Given this list of marker genes MYRF, CFL2, SACM1L, RGS3, HERC6, SBF2, RIN2, EIF4A2, FNDC3B, INHBB, NBEAL1, BAZ2A, DNAJB11, CELF2, NAA50, CSTF3, MAP4K4, VPS13B, CACHD1, FLNB, ERG, YTHDC1, MTX3 (NCBI Gene Id 345778), MYO5A, GGT7, CLCA3P, ASAP2, SLC25A25, FLI1, ZFYVE9, LMBRD2, ABCA1, NUFIP2, DLX6, NET1, GOLGA8G, AMOTL2, RASA1, MAP3K3, FZD7, BACH2, SEMA3A, NFE2L1, ACACA, SOX9, TM9SF4, GOLGA8F, SEC31B, ABHD17B, PLAGL2, CTNND1, FXN, CHKB (NCBI Gene Id 1120), ADAM19 (NCBI Gene Id 8728), PALS1, ACVR1B, SPOP, MDFIC, DAG1, TMEM178A, HIC2, PHRF1, SLC1A2, SELENOI, ZBTB10, FKBP3, RASA2, ANGPT2, CD47, TENT2, FSIP2, BLOC1S2, ADPGK, YTHDF2, VASN, XRN1, MPZL2, PTGFR, MRGBP, RBPMS, DPYSL2, AKAP12, CPEB4, GOLGA8EP, GARRE1, ZFP2, JPH1, TIRAP, TAGLN2, SRGAP2, GABARAPL2, SETD2, EIF4EBP2, LOX, PRRC2C, ANKRD28 (ankyrin repeat domain 28), IVNS1ABP, IRS1, CBFB, LARP4B, ACBD3, ABR, ACTR3, DUSP6, RTKN, ABLIM2, KIF21A, BRD8, USP46, ACVR2A, BBOF1, NUDT4, TNFRSF11B, TBPL1, SCAMP3, SPATS2, UBA6, SRGAP1, RREB1, CCDC25, PSD3, SCN3A, RASSF5, PAK5, STEAP4, CAMK1D, ADD3, H2AX, GOLGA8B, AP3S1, PXN, RNF31, NAP1L1, SOX11, LHFPL2, BEND4, TRIM2, DACH1, SRGAP3 (NCBI Gene Id 9901), ELMO1, REV3L (NCBI Gene Id 7807), KATNBL1, ZC2HC1C, FAM135A, QKI, INO80 (INO80 complex ATPase subunit), ZFYVE26, ERLIN1, PLCE1, EFNA3, ACTB, BSN, SNX27, CTNNBIP1, PDCD4, CCNL1 (NCBI Gene Id 57018), GPHN, RAB14, CARMIL1, HERC4, NUAK1, AFF2, PPP3CA, SEL1L3, MRPL48, SSH2, PTP4A2, BCR, LENG8, SMAD3, FBXO28, NSUN4, SENP2, EYA3, BOLA2, P4HTM, NEDD4L, MINDY4, PAN2, CDR2L, NEDD9, RGS7, CITED2, SEMA6A, CDC37L1, UXS1, CLINT1, ZDHHC9, SLC4A4, SLC6A15, PLCL2, AKIP1, SLITRK6, MAF, C1QL4, RBM4B, NDUFAF7, CDK6, GOLGA8A, SPSB4, RAPH1, ACTG1, CABP1, RSPO1 (R-spondin 1), SKP1 (NCBI Gene Id 6500), ACSL4, AKAP9, FOXO1, ARHGAP26, KIF1B, EIF4B, GLIS1, SLITRK4, ZNF423, EPB41L5, ZC3H11A, CSMD3, DYRK1A, HOXC11, PHLDB2, ARPC5, ARHGAP24 (NCBI Gene Id 83478), KLF5, AP1G1, FAXC, ATXN2, TGFBR2, FNDC3A, KDM2B, AKIRIN1, LNPK, CAPRIN1, YES1, UBE2Z, BAAT, here is a description of the gene set: Genes having at least one occurence of the motif AACTGGA in their 3' untranslated region. The motif represents putative target (that is, seed match) of human mature miRNA hsa-miR-145 (v7.1 miRBase). studied in species Homo sapiens Human Gene Set: AACTGGA_MIR145